Given this list of marker genes H2BC12L, EPG5, DEFA6, IFNL2, DEFA4, H2BC6, C17orf99, H2BC8, RNASE2, DEFB1, PIGR, H2BC10, APOA4, IL6R, IL6, CLDN2, GP2, LTF, FFAR3, PLA2G1B, XCL1, UMOD, CD160, BPIFB1, OTUD7B, H2BC7, DEFA3, DEFA1, RAB17, H2BC4, FAU, RPL39, DEFA1B, FFAR2, H2BC12, NOS2, RNASE3, IFNLR1, H2BC11, DEFA5, H2BC21, TREX1 (NCBI Gene Id 82474), CAMP, here is a description of the gene set: Human Gene Set: GOBP_ORGAN_OR_TISSUE_SPECIFIC_IMMUNE_RESPONSE studied in species Homo sapiens An immune response taking place in an organ or tissues such as the liver, brain, mucosa, or nervous system tissues.